Given this list of marker genes TAB2, EPHB1, ZNF813, CLTC, H3-5, CLPTM1, RBM27, CNOT2, LHFPL2, PCLO, ARK2C, WDTC1, TP53TG3C, ADGRG7, LRRC7, DAG1, COL25A1, EIF3J, UBE2D2, SLC9A2, CDC7, CALCR (NCBI Gene Id 799), THAP12, TECRL, FREM2, ZNF676, ZNF117, FKBP1A, CERS6, TFF3, PIM2, QKI, RAP1A, BOD1L2 (NCBI Gene Id 284257), DCAF4L2, UBR1, POU3F3, HSPA1A, ZBTB20, MAPK14, SLC29A3, TP53TG3B, BOD1, RBSN, SEMA4D, IL17RD, RASSF2, OLAH, TAF1D, PKP4, QTRT2, C15orf40, AKAP8, C4orf3, ZNF99, TNRC6B, TACC1, PCF11, CXADR, SPAG11B, ASF1A, CDH10, GAS7, ATP5F1E, NR2C1, SOX6, ARMCX3, FMNL2, BOK, MEF2A, ZNF765, PLCE1, FUT1, TP53TG3, DDX6, TC2N, N4BP1, SERINC3, ZNF486, here is a description of the gene set: species: Homo sapiens Human Gene Set: MIR412_3P from publication Chen Y, Wang X (PMID 31504780) Genes predicted to be targets of miRBase v22 microRNA hsa-miR-412-3p in miRDB v6.0 with MirTarget v4 prediction scores > 80 (high confidence targets).